Given this list of marker genes MT1E, ERICH2, XKR5, GLRX2, NUP42, PMF1, ISG20, TBC1D1, TRIP4, ULK1, RRAGD, MRRF, SLC35F5, MAP7, MSRA, RILP, OXCT1, ICOS, NCKAP1, DNAAF2, LONRF3, PTK2, IGFLR1, MLEC, APIP, SPART, GCSH, DNASE1L1, C6orf118, CPNE3, HS2ST1, CCDC120, KLHL23, DNAAF4, ANXA4, GSTO1, CCDC28B, BARX1, GMDS, ACTR3B, CEP57L1, LRRC57, NEDD1, NUCB2, UNC13A, IMMP2L, MAN1A2, POLA1, TIGD2 (tigger transposable element derived 2), UBE2F, RCN3, KCNK6, IMPA2, SPP1, TLCD3A, TMEM237, PPM1J (protein phosphatase, Mg2+/Mn2+ dependent 1J), MT2A, CBR3, GM2A, PRICKLE1, CD38, FAM83H, RARS2, ZFAND1, SNX12 (NCBI Gene Id 29934), EEF1AKMT1, GC, OCRL, CAPSL, PASK, TASP1, TEP1, LRRN1, GLRX, CMTM6, CDKN3, DPCD, BNIP2, TSLP, NT5E, PXMP2, TLE6, UBLCP1, TRMT5, POLK, WASHC2A, ANAPC13, GLOD4, BLTP3A, WIPI1, VMA21, UNC119, CTTN, RUFY3, POGLUT1, VCL (NCBI Gene Id 7414), TBC1D14, SLC39A8, TUBB2B, CDCA7L, GABRE, FBLN2, TUBB2A, COG6, ANO9, NINL, GNG12 (G protein subunit gamma 12), USP27X, LRRC8C, PRDX4, RHOQ, HCFC2 (host cell factor C2), IQCF5, GAPVD1, TRAIP, NCBP2, CTNNA1, RAD51AP1, SGO1, CD36, B3GNT7, NUSAP1, NEK2, KIAA1191, DECR1, RNF214, CLVS2, CYB5A, NEURL1B, SERPINB6, RAB32, PIK3C2G, KCNT1, SEPHS1, LAMC1, RECK, STX2 (NCBI Gene Id 6808), WDR6, PPP1R3B, MYO7A, C1orf131, SLC22A1 (NCBI Gene Id 6580), TUBGCP4, SNAP47, SYT12, NAV1, PFN2, PRKAG2, FANCI, LPGAT1, IFT57, RASIP1, FMNL2, CYP20A1, HAO1, SYNE3, TEFM, COX19, PROCR, TRIM35, BLVRA, PIH1D2, PPFIBP1, SPC25, C9orf85, STAB1 (NCBI Gene Id 23166), PON3, SLC35B1, COPS7B, KLF14, IFT88, BMP2K, MBNL2, RHOJ, ALG14, ANTXR2, FFAR4, TRABD, EXTL2, SLITRK5, FIRRE, STARD4, PJA2, TRMT44, HIBADH, PEPD, DPY19L3, CNDP2, TNFSF10, OSM, ERAP1, GLB1, C6orf141, FDX1, STX8, PLIN2, ACSL3, FABP5, MFSD1, here is a description of the gene set: from publication Peltier DC, Simms A, Farmer JR, Miller DJ (PMID 20483728) species: Homo sapiens Genes up-regulated in neuron cell line infected with western equine encephalitis virus: immature versus mature cells. Human neuronal differentiation alters responsiveness to innate immune stimuli and virus infections. We used microarrays to examine the transcriptional responses of the human BE(2)-C neuroblastoma cell line to infection with western equine encephalitis virus (WEEV). Human Gene Set: GSE16451_IMMATURE_VS_MATURE_NEURON_CELL_LINE_WEST_EQUINE_ENC_VIRUS_UP